The following is a description of a gene set: Recurrent episodes of redness, burning pain, and warmth of the extremities following exposure to heat or exercise with symptoms predominantly involving the feet. species: Homo sapiens Erythromelalgia Human Gene Set: HP_ERYTHROMELALGIA, and this is the list of marker genes: SH2B3, SCN9A, TP53, MPL, CALR, SCN10A, SCN11A, PIGA, TET2, JAK2